The following is a description of a gene set: Mouse Gene Set: GOMF_BIOACTIVE_LIPID_RECEPTOR_ACTIVITY Combining with a bioactive lipid and transmitting the signal across the membrane by activating an associated G-protein; promotes the exchange of GDP for GTP on the alpha subunit of a heterotrimeric G-protein complex. A bioactive lipid is a lipid for which changes in lipid levels result in functional consequences in a variety of cellular processes. studied in species Mus musculus, and this is the list of marker genes: Sphk1, Gpr31b, Gpr6, Ffar1, Lpar6, Gpr174, Lpar2, Lpar3, S1pr3, S1pr1, Sphk2, S1pr4, Gpr3, Lpar1, S1pr2, S1pr5, Lpar4